The following is a description of a gene set: Human Gene Set: MIR93_3P from publication Chen Y, Wang X (PMID 31504780) Genes predicted to be targets of miRBase v22 microRNA hsa-miR-93-3p in miRDB v6.0 with MirTarget v4 prediction scores > 80 (high confidence targets). species: Homo sapiens, and this is the list of marker genes: CNOT2, SNX33, KDM2A, TVP23C, AICDA, SFMBT1, SORBS2, SESN3, SMURF2, HEPACAM2, ATP9A, ZNF189, RAB4A, IL6ST, KCND2, TNRC6B, CCDC6, REPS1, STK32B, SLC39A9, GTF2I, OGT, CACNB2, PRPF8, PLAC8, REPS2, TVP23B, TPST1, PAX9, DCAF8, NFATC3, PEX11B, SYNJ1, USP3, TUT4, PHLDB1, MAN1C1 (NCBI Gene Id 57134), NR6A1, PRKAA1, PNN, ERC1, DNAJC27, ECRG4, CD58, CLEC4F, LDLRAD4, AIFM1, FBXL17, C5orf24, MIP, UBE2G2, EBF3, RCC1, DZIP1, CRACR2B, ING3, CA7, IFNK, TFB2M, LGALSL, KLHL2, MIOS, UNC5C, LAMC3, CPS1, SMAD2, HMGA2, MAP9, ZNF451, TTC21B, CEP97, DDI2, TBL1XR1, MTNAP1, MBP (myelin basic protein), PLPPR5, NTRK2, FAM149B1, PPP6C, CEBPZOS, SNRPE, ARF4, ZNF395, TOM1L1, MYLK4, DOCK4, SH3PXD2A, CNTNAP1, PRPS1, HDX, KIAA1549L, KPNA4, FETUB, COL4A3, SENP5, CCDC40, PIP5K1B, AEBP2, ZCCHC17, GLCCI1, CACNB4, SOX6, PWWP3B, TCHHL1, PLCXD2, PSD3, DLGAP1, CPNE8, PACSIN2, SPZ1, MBNL1 (muscleblind like splicing regulator 1), FRG2, PKIG, KLF12, NFASC, PXN, INO80, WNK3 (WNK lysine deficient protein kinase 3), TARDBP, EFHC2, ALPK3